Given this list of marker genes Ssna1, Akap9, Haus7, Sdccag8, Cep164, Cdk1, Cep250, Ahi1, Dctn3, Rab8a, Clasp1 (CLIP associating protein 1), Cep70, Haus4, Fbf1, Rab11a, Dctn1, Pafah1b1, Rpgrip1l, Cep192, Sfi1, Plk4, Sclt1, Dctn2, Actr1a, Kif24, Tubb4b, Tuba1a, Haus1, Csnk1d, Tctn2, Septin2, Haus5, Cep63, Ccp110, Cep89, Mapre1, Cep290, Dync1i2, Mks1, Cep83, Tuba4a, Cdk5rap2, Prkaca, Nphp1, Cep78, Cep76, Csnk1e, Tctn3, Ywhag, Plk1, Ywhae, Nedd1, Haus3, Cep43, Ninl, Cep41, Tubb4a, Nde1, Ofd1, C2cd3, Ppp2r1a, Haus6, B9d2, Cep162, Cep97 (centrosomal protein 97), Pcm1, Ckap5, Cep72, Tubb5, Rab3ip, Mark4, Iqcb1, Dynll1, Tubg1, Cetn2, Odf2, Haus2, Ttbk2, Tctn1, Dync1h1, Hsp90aa1, Haus8, Tmem67, Cc2d2a, B9d1, Nek2, Cep152, Nphp4, Cenpj, Tmem216, Cep57, Alms1, Cep135, Cep131, here is a description of the gene set: species: Mus musculus Anchoring of the basal body to the plasma membrane Mouse Gene Set: REACTOME_ANCHORING_OF_THE_BASAL_BODY_TO_THE_PLASMA_MEMBRANE